Given this list of marker genes Sis, Amy2a4, Amy2a3, Amy2a2, Chia1, Lct, Chit1, here is a description of the gene set: This event has been computationally inferred from an event that has been demonstrated in another species.<p>The inference is based on the homology mapping from PANTHER. Briefly, reactions for which all involved PhysicalEntities (in input, output and catalyst) have a mapped orthologue/paralogue (for complexes at least 75% of components must have a mapping) are inferred to the other species. Reactome Pathway: Digestion of dietary carbohydrate part of: Digestion studied in species Mus musculus electronically inferred by orthology from the curated human pathway